The following is a description of a gene set: from publication Chen Y, Wang X (PMID 31504780) species: Homo sapiens Human Gene Set: MIR1233_5P Genes predicted to be targets of miRBase v22 microRNA hsa-miR-1233-5p in miRDB v6.0 with MirTarget v4 prediction scores > 80 (high confidence targets)., and this is the list of marker genes: CIT, HNRNPLL, GSTM2, BAHCC1, TMEM106A, CYP11B1, PAK1, GCSAM, FRYL, LCE1A (late cornified envelope 1A), NDUFA5, TMEM245, GPSM3, SCN2A, NANP, KRT78, PCYT2, KLK10, LPP, TP53INP2, GNG13, CRY2, GON4L, UGT8, CDKN1C, NGFR (NCBI Gene Id 4804), NIPBL, PER1, MYO19, AP1G1, DCLK1, UCP3, PKLR, MAP7D3, NRIP2, ZFHX3, NFASC (NCBI Gene Id 23114), PAXBP1, PBX4, PTPRG (protein tyrosine phosphatase receptor type G), ZC4H2, PLA2G2D, YIPF3, XIRP1, PIKFYVE, B3GAT1, FXR1, DPF3, HOXB13, ZNF106, SNX9, HNRNPU, GARIN6, PLXNA4, BRPF3, PTP4A1 (protein tyrosine phosphatase 4A1), ELAVL1, MARCKSL1, TCAF2, WNT1 (NCBI Gene Id 7471), ATP13A2, UNC45B, SMIM21, ANKRD42, DIS3, INTS5, TM6SF2, GNAO1, TGM2, CHST9, BPTF, USB1, ADCYAP1R1, PPP1R8, MYO3B, FOXL2NB, ZER1, SEPTIN10, N4BP1, ANK1 (ankyrin 1), ADARB2, UNK, RPRD1B, ENSG00000255537 (novel transcript, antisense to FEZ1), RELN, PARP11, MPIG6B, TMEM104, KHSRP, BICRAL, ATAD5, TMED10, FOSB, C3orf38, SH2B3, SLC17A8, ATP7B, TNS1, ZNF318, MEF2A, PBX2, PTGFRN, PPME1, ARFGEF3